Given this list of marker genes CPT1B (NCBI Gene Id 150414), LRAT, CPT1A, CPT2, CPT1C, here is a description of the gene set: Catalysis of the transfer of a palmitoyl group to an oxygen atom on the acceptor molecule. studied in species Homo sapiens Human Gene Set: GOMF_O_PALMITOYLTRANSFERASE_ACTIVITY